The following is a description of a gene set: species: Mus musculus The process in which a microorganism (or other particulate material) is rendered more susceptible to phagocytosis by coating with an opsonin, a blood serum protein such as a complement component or antibody. Mouse Gene Set: GOBP_OPSONIZATION, and this is the list of marker genes: Myo18a, C4bp, Cfp, Ptx3, Pla2g5, Colec11, Sftpd, Cd47, Colec10, Fcnb, Lbp, Mbl2, Spon2, Zp3r